Given this list of marker genes Rad51d, Xrcc3, Xrcc2 (NCBI Gene Id 80583), Swi5, Rad51b, Rad51c, Sfr1, here is a description of the gene set: studied in species Mus musculus Mouse Gene Set: GOCC_DNA_RECOMBINASE_MEDIATOR_COMPLEX A protein complex containing accessory proteins which bind a recombinase (e.g. Rad51) and bind single-stranded DNA (ssDNA), and promote nucleation of the recombinase onto ssDNA through facilitating recombinase-RPA exchange.